The following is a description of a gene set: from publication Chen Y, Wang X (PMID 31504780) species: Mus musculus Genes predicted to be targets of miRBase v22 microRNA mmu_let_7d_3p in miRDB v6.0 with MirTarget v4 prediction scores > 80 (high confidence targets). Mouse Gene Set: LET_7D_3P, and this is the list of marker genes: Myf5 (myogenic factor 5), Nmur2, Cyp2c55, Mex3c, Insyn2a, Samd8, Krtap19-5, Klf11